Given this list of marker genes SH3BP5, BBS12, TRIM27, TEX10, XPOT, GXYLT1, STK10, VAPB, FBXO5, UNG, RBFA, TP53BP1, TMEM109, DPH5, HELQ, TMEM11, TSC22D1, NUDT5, FAM107B, RPL39, EIF4G2, ENSG00000267882, CZIB, GTF2IRD2, DCDC2B, PABPC1, C1QBP, GPR35, SETD5, ZNF708, MAP4K4, PSTK, TRIAP1 (TP53 regulated inhibitor of apoptosis 1, NCBI Gene Id 51499), STK26, SS18L2, TFRC, WDFY2, SURF6, MRPS2, TIMM9, TSC1, RGS2, PEBP1, PDIK1L, GGA2, TSPYL2, POLR2H, MRPL42, AGL, VAMP1, C12orf43, TNFAIP8L2, CCDC30, KRI1, PARD6G, SERP1, DTWD2, MATR3, NIFK, HIGD2A, C3orf70, DBP, YPEL4, MTO1, AGBL5, SEPSECS, TIFAB (TIFA inhibitor), CTU2, ZNF799, RASSF7, CLNS1A, MRRF, SZRD1, CASD1, BIVM, RFC1, TRAPPC2B, CRTC3, KBTBD7, DDI2, BTBD1, TMEM60, ROMO1, PCDHB5, MFSD2B, CFL1, CBX7, WDR75, APEX1, POGLUT1, RNF126, MFNG, CCT4, LSM10, TRMT112, PRADC1, MTSS1, EMILIN1, WWP1, NLK, HOOK3, MAPK14, YPEL2, SDAD1, ZNF566, C6orf136, TMED9, ATP2A2, SLC48A1, POGLUT2, CHKB, C15orf61, MRPL12, AFF2, ZNRF1, PUM3, YY1, TIMM10, RPS5, PSMD11, TSN, COQ5, ADGRA2, ESRRA, OSBPL2, FERMT3, CREBL2, NUDT4, HNRNPR, FGF8, MRPL18, KDF1, PSMG2, NAA50, GNL3, NOL9, FARSB, TINF2, LAMTOR2, USP10, MXD4, POLE3, CTDSP2, ASPA, ABHD4, MRPL44, DDX10, C1orf54, ITLN1, PLIN3, PARP1, PHB2, IDH2, RPSA, MDH1, SLC27A1, KBTBD8, CCDC93, CDK2AP1, DUSP12, KLHDC2, ZZZ3, MAPRE2, TPRA1, HNRNPK, TSPYL4, IPO4, HPS4, TRIM37, RPS26, IL16, GABRB2, MCOLN2, FKBP15 (NCBI Gene Id 23307), TP73, PER1, HAO2, SLC1A7, CCDC115, DDX46, CTBS, TIMM8A, RNF166, PBX2, ZNF507, PHF10, NAGPA, MSRB2, EDA2R, PBXIP1, DOCK1, PPP1R12B, ARRB2, SPATS2L, BLOC1S5, PITPNB, DTYMK, CDKN2AIPNL, ZNF394, TCN2, here is a description of the gene set: Human Gene Set: GSE46606_DAY1_VS_DAY3_CD40L_IL2_IL5_STIMULATED_IRF4HIGH_BCELL_UP Genes up-regulated in CD40L and IL-2 IL-4 IL-5 stimulated at day 1 B cell IRF4high versus CD40L and IL-2 IL-4 IL-5 stimulated at day 3 B cell IRF4high. from publication Ochiai K, Maienschein-Cline M, Simonetti G, Chen J, Rosenthal R, Brink R, Chong AS, Klein U, Dinner AR, Singh H, Sciammas R (PMID 23684984) species: Homo sapiens Temporal analysis of B cell activation in vitro using CD40L and IL-2/4/5 cytokines in wild type Irf4+/+ B cells or in mutant Irf4-/- B cells harboring a tet-inducible allele of Irf4. IRF4 expression was restored, or not, in the Irf4-/- background by culturing in the presence of low or high concentrations of doxycycline. The results provide insight in the role of IRF4 expression levels in coordinating different programs of B cell differentiation.